The following is a description of a gene set: An epigenetic gene regulation mechanism that positively regulates gene expression by demethylation of cytosine residues in chromosomal CpG islands. CpG islands are genomic regions that contain a high frequency of the CG dinucleotide and are often associated with the transcription start site of genes. studied in species Mus musculus Mouse Gene Set: GOBP_POSITIVE_REGULATION_OF_GENE_EXPRESSION_VIA_CHROMOSOMAL_CPG_ISLAND_DEMETHYLATION, and this is the list of marker genes: Ogg1, Apex1, Apobec1, Tet1, Zmpste24, Tet2, Egr1, Apobec2, Tet3, Ftx, Aicda